Given this list of marker genes OGDH, UQCRQ, DCLK2, ZMIZ1, SCYL2, FGFR2, DISC1, TUBA1A, UNC5D, PLXNA3, FOXG1, GBA1, BCL6, ATP7A, SLC4A10, here is a description of the gene set: species: Homo sapiens The process in which a neuroblast or one of its progeny commits to a pyramidal neuron fate, migrates from the ventricular zone to the appropriate layer in the cortex and develops into a mature neuron. Human Gene Set: GOBP_PYRAMIDAL_NEURON_DIFFERENTIATION